The following is a description of a gene set: Cluster T7 of genes with similar expression profiles in thymic T lymphocytes after FOXP3 loss of function (LOF). Regulatory CD4+ T cells (Tr cells), the development of which is critically dependent on X-linked transcription factor Foxp3 (forkhead box P3), prevent self-destructive immune responses. Despite its important role, molecular and functional features conferred by Foxp3 to Tr precursor cells remain unknown. It has been suggested that Foxp3 expression is required for both survival of Tr precursors as well as their inability to produce interleukin (IL)-2 and independently proliferate after T-cell-receptor engagement, raising the possibility that such 'anergy' and Tr suppressive capacity are intimately linked. Here we show, by dissociating Foxp3-dependent features from those induced by the signals preceding and promoting its expression in mice, that the latter signals include several functional and transcriptional hallmarks of Tr cells. Although its function is required for Tr cell suppressor activity, Foxp3 to a large extent amplifies and fixes pre-established molecular features of Tr cells, including anergy and dependence on paracrine IL-2. Furthermore, Foxp3 solidifies Tr cell lineage stability through modification of cell surface and signalling molecules, resulting in adaptation to the signals required to induce and maintain Tr cells. This adaptation includes Foxp3-dependent repression of cyclic nucleotide phosphodiesterase 3B, affecting genes responsible for Tr cell homeostasis. species: Mus musculus Human Gene Set: GAVIN_FOXP3_TARGETS_CLUSTER_T7 from publication Gavin MA, Rasmussen JP, Fontenot JD, Vasta V, Manganiello VC, Beavo JA, Rudensky AY (PMID 17220874), and this is the list of marker genes: PTP4A2, MTF2, SNRPB, EIF3L, MKRN1 (NCBI Gene Id 392799), GUK1, EIF3H, FAM50A, CCDC22, PRPS1, SAMSN1, AMD1, RUVBL1, DDX54, TPR, BCL2L11, STAT1, STAMBPL1, MARCKS, AKR1B1, PPM1M, RPL32, UNC119B, STRAP, MTHFD1, JAK2, ENO1, VIM, LRPAP1, UCK2, HCLS1, NFKB2, CYBA, KLHDC2, PSMB8, CAST, NRGN (neurogranin), BACH2, ATP5MC2, RPL10, DCTN3, SAR1A, ADGRG3, SUPT4H1, HNRNPF, CHCHD2, IK, ECH1, GDI2, MRPL46, MCM6, RBM33, CDC37, RAC2, LGALS1, FIS1, USE1, SPECC1, LIG1, PDRG1, PNP, RPL18, QARS1, MTMR9, GPR83, ATP5F1B, OAZ1, STRN3, PSTPIP2, RAP1GDS1, SMO, TIMM13, CNTRL, LONP1, MDH1 (NCBI Gene Id 4190), KCNN4, GMPS, EIF3B (eukaryotic translation initiation factor 3 subunit B), CCT2, RPS7, CD2, UGP2, PPDPF, NKG7, CD24, SCART1, EIF3M, CD47 (NCBI Gene Id 961), ITM2B, NDUFA9, ANXA6, JAK1, TRBV11-3, XPO4, RPS9, FTL, ALG5 (NCBI Gene Id 29880), MYL6, REEP5, RTCB